Given this list of marker genes Slc27a1, Slc7a11, Slc26a10, Slc25a26 (NCBI Gene Id 71253), Lrrc8a, Slc25a47, Slc16a6, Nherf1, Slc26a9, Slc6a6, Slc26a8, Mgst1, Slc1a4, Slc6a13 (NCBI Gene Id 14412, solute carrier family 6 (neurotransmitter transporter, GABA), member 13), Slc13a3, Slc25a17, Slc26a2, Abcg2, Slc25a39, Slc25a42, Slc44a4, Lrrc8c, Slc25a19, Slc36a1, Slc22a8 (NCBI Gene Id 19879), Mfsd12, Slc26a7, Slc47a1, Slc3a2, Gja1, Slc33a1, Slc35b3, Slc43a2, Slc26a1, Slc7a9, Abcc4, Slc25a40, Slc1a2 (solute carrier family 1 (glial high affinity glutamate transporter), member 2), Ucp2, Slc26a3, Slc35f3, Abcc1, Slc3a1, Slc22a2, Slc5a6, Slc19a3, Slc6a11, Slc26a5 (solute carrier family 26, member 5), Slc26a11, Slc22a1, Slc7a5, Slc25a16, Slc1a1, Slc7a13, Slc35b2, Slc26a6 (NCBI Gene Id 171429), Slc26a4 (NCBI Gene Id 23985), Nfe2l1, Slc19a2, Ctns, Lrrc8d, Slc25a10, Slc13a1, Racgap1, Abcd1, Abcc2, Abcc5, here is a description of the gene set: The directed movement of compounds that contain sulfur, out of or within a cell, or between cells, by means of some agent such as a transporter or pore. Mouse Gene Set: GOBP_SULFUR_COMPOUND_TRANSPORT studied in species Mus musculus